The following is a description of a gene set: Any process that results in a change in state or activity of a cell or an organism (in terms of movement, secretion, enzyme production, gene expression, etc.) as a result of a ozone stimulus. Mouse Gene Set: GOBP_RESPONSE_TO_OZONE studied in species Mus musculus, and this is the list of marker genes: Il1a, Scgb1a1, Cat, Edn1, Tacr1